Given this list of marker genes Polr2a, Cavin1, Smn1, Polr1h, Polr3k, Scaf4, Zgrf1, Ssu72, Zmpste24, Ttf2 (NCBI Gene Id 99859), Lipe, Maz, Mterf2, Xrn2, Ttf1, Prmt5, Wdr82, Scaf8, Dhx9, Mterf1a, Pcf11, Per2, Setx, Zc3h4, Mterf1b, Wnk1, here is a description of the gene set: The completion of transcription: the RNA polymerase pauses, the RNA-DNA hybrid dissociates, followed by the release of the RNA polymerase from its DNA template. studied in species Mus musculus Mouse Gene Set: GOBP_DNA_TEMPLATED_TRANSCRIPTION_TERMINATION